Given this list of marker genes DLL3, ESR2, FGF9, DLL1, ESR1 (estrogen receptor 1), DLL4, EGF, here is a description of the gene set: Pathway Definition from KEGG: E2 -> ESR1/2 => (EGF,FGF9,DLL) species: Homo sapiens E2 to nuclear-initiated estrogen signaling pathway. Pathway ID: N01364. Pathway type: Env factor. Pathway class: nt06227 Nuclear receptor signaling. Human Gene Set: KEGG_MEDICUS_ENV_FACTOR_E2_TO_NUCLEAR_INITIATED_ESTROGEN_SIGNALING_PATHWAY